The following is a description of a gene set: species: Homo sapiens Human Gene Set: SA_B_CELL_RECEPTOR_COMPLEXES Antigen binding to B cell receptors activates protein tyrosine kinases, such as the Src family, which ultimate activate MAP kinases., and this is the list of marker genes: GRB2, MAPK8IP3, ATF2, LYN, PAPPA, SYK, BCR (NCBI Gene Id 729775), JUN, VAV2, SHC1 (NCBI Gene Id 6464), RPS6KA1, RAC1, VAV1, VAV3, HRAS, FOS, RPS6KA3, ELK1, MAPK1, MAP3K1, BLNK, SOS1, MAP2K1, MAPK3 (mitogen-activated protein kinase 3)